The following is a description of a gene set: The formation of a lumen by hollowing out a solid rod or cord. species: Mus musculus Mouse Gene Set: GOBP_TUBE_LUMEN_CAVITATION, and this is the list of marker genes: Shh, Edar, Nfib, Eda, Tgm2, Cdh1